Given this list of marker genes Rora, Btrc, Nps, Bmal1, Mtnr1b, Thrap3, Nlgn1, Ghrh, Adora2a, Uts2r, Kat5, Clock, Casp1, Prkg1, Timeless, Pmch, Nkx2-1, Ghrhr, Ptger4, Ptger3, Alb, Bmal2, Rorc, Fbxw11, Npy2r, Ghrl, Nr1d1, Uts2, here is a description of the gene set: studied in species Mus musculus Mouse Gene Set: GOBP_POSITIVE_REGULATION_OF_CIRCADIAN_RHYTHM Any process that activates or increases the frequency, rate or extent of a circadian rhythm behavior.